The following is a description of a gene set: Human Gene Set: GSE6269_E_COLI_VS_STREP_PNEUMO_INF_PBMC_UP studied in species Homo sapiens Genes up-regulated in comparison of peripheral blood mononuclear cells (PBMC) from patients with acute E. coli infection versus PBMC from patients with acute S. pneumoniae infection. Each infectious agent represents a unique combination of pathogen-associated molecular patterns that interact with specific pattern-recognition receptors expressed on immune cells. Therefore, we surmised that the blood immune cells of individuals with different infections might bear discriminative transcriptional signatures. Gene expression profiles were obtained for 131 peripheral blood samples from pediatric patients with acute infections caused by influenza A virus, Gram-negative (Escherichia coli) or Gram-positive (Staphylococcus aureus and Streptococcus pneumoniae) bacteria. Thirty-five genes were identified that best discriminate patients with influenza A virus infection from patients with either E coli or S pneumoniae infection. These genes classified with 95% accuracy (35 of 37 samples) an independent set of patients with either influenza A, E coli, or S pneumoniae infection. A different signature discriminated patients with E coli versus S aureus infections with 85% accuracy (34 of 40). Furthermore, distinctive gene expression patterns were observed in patients presenting with respiratory infections of different etiologies. Thus, microarray analyses of patient peripheral blood leukocytes might assist in the differential diagnosis of infectious diseases. from publication Ramilo O, Allman W, Chung W, Mejias A, Ardura M, Glaser C, Wittkowski KM, Piqueras B, Banchereau J, Palucka AK, Chaussabel D (PMID 17105821), and this is the list of marker genes: LDB2, RPSAP20, HEG1, NR1D2, LAMP3, CASKIN2, JUN, NUFIP1, PARP11, RPS12, AIMP2, SPTLC3, CDC14A, INPP4B, SEPTIN7, KRTAP1-3, ADGRL1, CLN8, NREP, CCDC28B, CDKN1C, HADH, RNASEH2B, EIF4A1, PLAG1, PNPLA3, KLK12, PRSS1, GFPT2, BAHD1, SRR, DPP4, MS4A5 (membrane spanning 4-domains A5), RAB25, ME3, MLLT11, TSPYL5, PPP1R17, DNAH6, URB2, XPNPEP3, DLEU1, ZFP36L1 (ZFP36 ring finger protein like 1), RPSAP44, AKAP7, NKTR, ADCK2, RLN2, DDX27, CTAG1B, EHD2, CKMT2, ANGEL1, C21orf91, FKBP10, SEPTIN9, KLF12, POLR2G (RNA polymerase II subunit G), ADA, HLA-DRB1, COA1, ERBB2, ATP6V0E2, AUTS2, ATP8A2, CCDC170, SGCG, CCL8, PHF8, AK5, CD69, CYP4A11, KLRG1 (NCBI Gene Id 10219), ENPP2, CYLD, RTP4 (NCBI Gene Id 64108), LRRC20, SOX4, GP2, SLC4A7, EXTL2, ID3, ELL3, OGFOD3, ATXN10, SCML2, TSPAN6, SNED1, SERPINF1, F12, TRIM23 (tripartite motif containing 23), ASIC1, MAPKBP1, DDX17, CAMSAP2, TUBB, FOXJ2 (NCBI Gene Id 55810), URB1, NET1, RAD1, PLSCR3, ROBO1, IGF2BP3, CDH20, TCF20, CD6, PRMT5, RHOBTB3, REG1B, ACTR5, OR2A20P, SHANK2, ZBTB25, OBSCN, CPED1, OR7A17, INHBE, ULK2, UBE2NL, MTHFD1 (NCBI Gene Id 4522), LEPROTL1, PFKM, HPX, FETUB, NR5A2, ARL4C, SLC25A5, SYNJ2, RBM26 (NCBI Gene Id 64062), ZNF135, KRT12, LPIN2, TMCO6, EXO5, PIN4 (peptidylprolyl cis/trans isomerase, NIMA-interacting 4), YARS1, DCAF11, GAL3ST4, MEG3, SUSD4, ESR1, HNRNPA3P17, KPNB1, GMDS, ST3GAL5, HNRNPA1P37, NPAS2, JAKMIP2, PDE9A, GEMIN2, OPTN, APOH, ITM2A, TNIK, LDAH, DGCR6, ING4, PTPRD, SUGP1, MTG1, SATB1, PCBP2, GTF3C4, CHI3L2, GPA33, DRD1, COX6CP1, DNPH1, HPGD